The following is a description of a gene set: Pathway Definition from KEGG: OspF -| (ERK,p38) studied in species Homo sapiens Human Gene Set: KEGG_MEDICUS_PATHOGEN_SHIGELLA_OSPF_TO_TLR2_4_MAPK_SIGNALING_PATHWAY Shigella OspF to TLR2/4-MAPK signaling pathway. Pathway ID: N01283. Pathway type: Pathogen. Pathway class: nt06517 TLR signaling., and this is the list of marker genes: MAPK3, MAPK14, MAPK13, MAPK12, MAPK11, MAPK1